The following is a description of a gene set: Human Gene Set: MIR8062 species: Homo sapiens from publication Chen Y, Wang X (PMID 31504780) Genes predicted to be targets of miRBase v22 microRNA hsa-miR-8062 in miRDB v6.0 with MirTarget v4 prediction scores > 80 (high confidence targets)., and this is the list of marker genes: NOX4, RBM26, VAMP4, GPRC5B, SLC35G1, WASL (WASP like actin nucleation promoting factor), NRIP1, NFIB, PAQR3, RAG1, RREB1, SHOC2, ATOSA, METAP1, PAFAH1B1, PAM, DDR1, PARP16, CAPZA2, RBL2, LAMTOR3, FRYL, RPS6KB1, LRP2 (LDL receptor related protein 2), ARHGAP6, IDI2, HYOU1, HSPD1 (heat shock protein family D (Hsp60) member 1), WDCP, TAF5L, VAPA, NCOA4, TNFSF8, RHOBTB3, TBL1XR1, CNKSR2, AKAP10, F9, PHEX, ZEB2, LARP1, VWC2, TDO2, UGCG, PHB1, PDE5A, NDNF, AAK1, ACBD3, SMARCA5, RFX1 (regulatory factor X1), PRIM2, FNDC3B, CEP63, UGT2A2, UBE2E2, CNOT6L, ELN, KRAS, MAPK1IP1L, MEP1B, ANKRD6, SMC2, TOM1L1, YWHAH, POGZ, CCDC88A, CAV1, HHIP, SEC24D, SLC12A6, NEDD4, CREBZF, SATB2, UGT2A1, DPP10, CREM, CNTN5, UXS1, LIN28B, ABCA3, RGS21, OCA2, AMELX, SCAI, YTHDF2, NFX1, LEPR (NCBI Gene Id 3953), RPRD1A, LRRC8D, PRKX (protein kinase cAMP-dependent X-linked catalytic subunit), SLITRK4, FHIP2A, PKN2, PPM1A, SEMA5A, GXYLT1, CDH10, LRRC59, CIAO1, KLHL4, MRPL53, ANO6, KCNMA1, ZBTB4, ARHGEF12, AMZ1, ZBTB1, MAP3K4